Given this list of marker genes Ap3b1, Cnih2, Kif1a, Ap3s2, Ap3m1, Bloc1s1, Bloc1s5 (biogenesis of lysosomal organelles complex-1, subunit 5, muted), Bloc1s6, Ap3d1, Madd, Borcs5, Kif1b, Snapin, Dtnbp1, Map2, Bloc1s3, Ap3m2, Bloc1s4 (NCBI Gene Id 70328), Bloc1s2, Trim46, Ap3b2, Ap3s1, here is a description of the gene set: Mouse Gene Set: GOBP_SYNAPTIC_VESICLE_CYTOSKELETAL_TRANSPORT species: Mus musculus The directed movement of synaptic vesicles along cytoskeletal fibers such as microfilaments or microtubules within a cell, powered by molecular motors.